Given this list of marker genes SESTD1, KSR1, SPATS2L, MGLL, FNIP2, MARCKS, APOBEC3A, TBC1D8, ZBTB10, ULK1, STAT1, CDKN1A, PKD2, ISG15 (ISG15 ubiquitin like modifier), SAT2, ULK2, UBALD2 (NCBI Gene Id 283991, UBA like domain containing 2), NOD2, LINC00487, IPO4 (NCBI Gene Id 79711), REC8, LAP3, ETV6, CTTN, ARHGAP31, SAR1A, UBE2E3, DTX3L, AKAP8, PARP12, SAMD9L, TMEM255A, PEA15, SIPA1L2, IFIT1, BLVRA, TNS3, HAUS8, HPSE, AGPAT1, TRIM25, SDSL, ZNF185 (NCBI Gene Id 7739), RIN3, ZDHHC3, HMGXB4 (HMG-box containing 4), OASL, PLSCR1, RCC2, HERC5 (NCBI Gene Id 51191), MNT, CAPN2, RMC1, RCN1, ZNFX1, CIMAP1B, PIK3AP1, OAS2, METRNL, AGPAT3, ADAR, GALNT6, ZBED1, SIGLEC1, MAN2A2, EMILIN2, TENT5A, HESX1, FXYD6, ST3GAL5, IFI27, PIWIL4, TPM3, FBXO6, SAMD4A, APOL6, PTK2, MARK3, PML, CKAP4, RELA, VDR, RGL1, SCO2, MAFG, SLC9A9, VSIG10L, RIN2, CLASP1, XAF1, NEK3, STON1, MAFB, SNN, NCOR2, NEXN, IGF2BP3, IRF7, LAMP3, TRIM22, DDX60, USP25, BAP1, STAT2, RFPL3S (RFPL3 antisense, NCBI Gene Id 10737), FTH1P5, ZBP1, LY6E, SNHG20, HMOX1, PPM1A, MIDN, GMPR, MX1, GLUL, MYLK, MVB12A, NPEPL1, DHX58, ARHGAP21, BLTP3A, UTRN, TPP1, IFIT5, EPSTI1, RSAD2, RUBCN, SHFL, PWWP2B, RAP2B, SLU7, RBBP8, MX2, MTHFR, TRIM69, SASH1, UBAP2L, OAS1, RAC1, NCOA7, KIAA1958, PARP9, SP100, ABL1, LILRA1, SH2B3, CTSL, TYMS, VPS11, SCARB2, XPNPEP1, USP42, ELF4, ZCCHC2, RNASEH1, JUP, RHOBTB1, CMTR1, CHRAC1, PARP14, WASL, DDX60L, DAB2, MYOF, IFI44L, ASAP2, CHAF1A, LYN, KLF10, EIF2AK2, UPP1, FMNL2, HERC6, IFI6, SUSD1, CORO7, SMAD7, GTPBP1, OAS3, IFIT3, KLF11, DENND1A, PEAR1, KIAA0513, PNPT1, PHF11, USP18, PHACTR2, COLGALT1, LILRB2, PARP11, EXT1, LPP, SERPING1, TXNDC11, LDLR, RYBP, here is a description of the gene set: Human Gene Set: GSE13485_DAY7_VS_DAY21_YF17D_VACCINE_PBMC_UP from publication Querec TD, Akondy RS, Lee EK, Cao W, Nakaya HI, Teuwen D, Pirani A, Gernert K, Deng J, Marzolf B, Kennedy K, Wu H, Bennouna S, Oluoch H, Miller J, Vencio RZ, Mulligan M, Aderem A, Ahmed R, Pulendran B (PMID 19029902) The immune responses generated by YF-17D by profiling genes in 25 vaccine recipients were accessed at days 1, 3, 7, and 21 post-vaccination compared to pre-vaccination in PBMCs. The immune responses generated by YF-17D by profiling genes in 25 vaccine recipients were accessed at days 1, 3, 7, and 21 post-vaccination compared to pre-vaccination in PBMCs. Genes up-regulated in comparison of unstimulated peripheral blood mononuclear cells (PBMC) 7 days after stimulation with YF17D vaccine versus PBMC 21 days after the stimulation. studied in species Homo sapiens